The following is a description of a gene set: species: Homo sapiens Human Gene Set: chr6p21, and this is the list of marker genes: RNA5SP207, RN7SL200P, MIR5004, LTA, RNA5SP206, RPL10A, SNORA38, NFKBIL1, RN7SL502P, ARMC12, SAPCD1, HLA-DPB1, MICA, NOTCH4, UQCC2, NCR3, HSPA1B, LTB, HLA-DQB1, GRM4, USP8P1, CUL9 (cullin 9), RPL7P25, VPS52, LY6G6F-LY6G6D, ENSG00000290049, MIR6834, CRIP3, RNY4P10, C4B-AS1, LINC03040, LINC01276, BAK1, C6orf132, CYP21A1P, PSMB8, DXO, MRPL14, RPS10, RPL12P2, MIR6721, LINC02520, LY6G5B, GUCA1A, MTCO3P1, FOXP4, MOCS1, HMGA1, PPIL1, PRRT1, NPM1P51, HLA-DRB9, RNVU1-33, LY6G5C, GLP1R, SLC22A7, CLPS, C4A-AS1, HSPE1P11, MSH5, CMTR1, BNIP5, ENSG00000228559, SAPCD1-AS1, TREML5P, POLH-AS1, XPO5, TNXB, VWA7, RNU1-88P, HCP5, KLC4-AS1, IP6K3, ENPP4, FANCE, COL11A2P1, MSH5-SAPCD1 (NCBI Gene Id 100532732), ATP6V1G2, RPS18, BICRAL, TMEM63B, MRPS10, RUNX2-AS1 (RUNX2 antisense RNA 1), RN7SL811P, NFKBIE, DINOL, BTBD9-AS1, ITGAEP1, RSPH9, PPT2-EGFL8, HLA-DRB6 (NCBI Gene Id 3128), PPT2, MIR3135B, CSNK2B, AGER, C4B, PSORS1C1, ENPP5, ENSG00000293066, RPL15P4, RPL36AP5, KRT18P9, KCNK5, MIR4641 (NCBI Gene Id 100616178), HLA-S, EHMT2, ZBTB12, MIR5690, APOM, SLC35B2, CIMIP3, TFGP1, DLK2 (delta like non-canonical Notch ligand 2), MICB, ENSG00000206977, RNU6-890P, RNY3P15, KCTD20, B3GALT4, STK38, RPL32P15, DNAJC2P1 (DNAJC2 pseudogene 1), DAXX, UNC5CL, C6orf89, HLA-DQB2, KLC4, ATP6V0CP3, TAP2, BLTP3A, TFEB, ENSG00000307671, RNF8, CLIC5, MIR6873, BTBD9, ENSG00000304688, SRF, YIPF3, TNF, HLA-DRA, MIR4462, SLC29A1, HLA-DPB2, TAP1, RPL32P1, RBM22P4, SRPK1, HLA-DPA1, SNRPC, RNU6-250P, DNPH1, HLA-DQB1-AS1, PPP1R18, PHF1, KLHDC3, PBX2, HTATSF1P1, SPDEF, NRM, ANKRD36P2, RN7SL26P, TCP11 (NCBI Gene Id 6954), TREML3P, GUCA1B, MIR4647, DDAH2, LINC02976, LAP3P2, HSP90AB1, LY6G6F, GPSM3, MIR6835, RN7SL465P, FLOT1, ETV7, MIR4640, RNU6-1113P, FOXP4-AS1, IER3-AS1, ENSG00000232080, PPIAP9, ENSG00000293992, FKBPL, VARS2, PPP1R2P1, RN7SL353P, TREM1, ATF6B, HCG22, ANKRD18EP, NELFE, TREM2, AGPAT1 (NCBI Gene Id 84827), FRS3, HLA-DOA, HNRNPA1P2, MUC21, DDR1-DT, SNORD52, KIFC1, TEAD3, C6orf226, C2, ATAT1, TAPBP, ZBTB22, CCHCR1, PSMB8-AS1, USP49, OARD1, COX6A1P2, SRSF3, RPL7P4, C6orf47-AS1, GNMT, LHFPL5, MIR7159, RPL35P2, ANKS1A, MDC1-AS1, CYCSP55, SLC39A7, TBC1D22B, SMIM40, ENSG00000226454, E2F4P1, BYSL, GNL1, C6orf15, RN7SL403P, ZFAND3, RN7SL285P, PANDAR, ZDHHC20P2, MIR6833, RPL36P9, COL11A2, ENSG00000283573, DAAM2-AS1 (DAAM2 antisense RNA 1), RNU6-754P, ABHD16A, SPATS1, BRPF3-AS1 (BRPF3 antisense RNA 1), PGC, NCR2, LINC00951, MIR3925, LRFN2, MYMX, LRRC73, ILRUN-AS1, MIR1236, RNU6-761P, WDR46, SAYSD1, HLA-DOB, APOBEC2, TNXA, NAPGP2, ENSG00000295882, MIR7111, HLA-DPA2 (NCBI Gene Id 646702), RNU6-603P, TREML2, HSPA1L, CUL7, TOMM6, DDX39B, GTPBP2, DNAH8-DT, GTF2H4, POLH, TBCC, SYNGAP1, KIF6, ZNF76, RNU1-54P, LSM2, ENSG00000284954, MCCD1, EHMT2-AS1, LINC02569, C4A, TSPO2, ENSG00000252218, ZNF318, TULP1, BTNL2, RPL35AP4, BAG6, MIR586, MICA-AS1, ATP6V1FP1, BRD2, HLA-DMB, ITPR3, SNORD84, ENSG00000301948, SNORD48, DPRXP2, SUPT3H, LYPLA2P1 (NCBI Gene Id 92067), RING1, EXOSC8P1, SKIC2, PPARD, RN7SKP186, RN7SL273P, LINC02571, MLN, TRERF1, WASF5P, ENSG00000308921, ENSG00000289456, VARS1 (NCBI Gene Id 7407), UQCRHP1, UBR2, PSORS1C2, TTBK1, NUDT5P1, CLPSL1, MRPS18B, VEGFA, MED20, SLC44A4, SCUBE3-AS1, ANKRD39P1, RPL34P14, HCG25, RPL23P6, LINC00336, MDGA1, MPIG6B, PTMAP1, NUDT3, RAB44, RNU1-61P, HLA-C, RN7SL748P, HLA-B, CFB, MIR877, RPL12P1, ENSG00000304146, HCG20, STK19B, NFYA, RXRB, HLA-DPA3, RUNX2, HLA-DMA, CLPSL2, MIR6832, MAPK13, PI16, RPL3P2, PEX6 (NCBI Gene Id 5190), PTCRA, MIR4646, CLIC1, TMEM217B, MIR1275 (NCBI Gene Id 100302123), STK19, AIF1, HCG21, IFITM3P3, ITPR3-AS1, LINC00243, RPL12P47, MUCL3, MIR219A1, KCNK16, MAD2L1BP, FGD2, LINC01512, DHFRP2, MRPL2, DHX16, LINC01149, CDSN, EGFL8, CCDC167, RNU6-850P, PRPH2, PPP1R10, CUTA, LINC01016, TJAP1, POLR1C, MICB-DT, SCIRT, SLC26A8, PTK7, POLR2LP1, HLA-DRB5, FKBP5, HSD17B8, RNU6-643P, GLO1, ABCC10, RPS10-NUDT3, KCNK17, GPR166P, DNAH8-AS1, RPS10P13, HLA-DQA2, PSORS1C3, ZNF70P1, ILRUN, ENSG00000293636, TSBP1-AS1, LINC02570, TSBP1, IER3, LINC02537, DNAH8, GUCA1ANB-GUCA1A, SNHG32, PXT1, MIR4642, TMEM151B, MKRN6P, TREML4, ENSG00000272217, ENSG00000212579, RPS15AP19, ENSG00000289047, DEF6, SNORD117, RPS2P29 (NCBI Gene Id 93638), ZFAND3-DT, CAPN11, MIR6780B, LY6G6C, LST1, TCTE1, HCG27, HLA-Z, LY6G6D, TCF19, SYNGAP1-AS1, MIR6891, NUDT19P4, RNU6-1133P, PSMB9, RPS2P28, CYP21A2, PPP2R5D, RRP36, ADCY10P1, TAF11, RNF5, POU5F1, CNPY3, MUC22, PIM1, C6orf47, MDFI, ETV7-AS1, DDR1, ABCF1, SCUBE3, PFDN6, CMPK1P1, MEA1, PRRC2A, HLA-DRB1, HLA-DQA1, DDX39B-AS1, C2-AS1, GPANK1, NEU1, BRPF3, TUBB (NCBI Gene Id 95295), C6orf136 (chromosome 6 open reading frame 136), TAF8, DAAM2, TUBBP9, FGFR3P1, CDKN1A, PNPLA1, AARS2, MYL12BP3, MTCH1, LY6G6E, MDC1, RPL7L1, MIR3934, TREML1, PRICKLE4, SFTA2, RPL24P4, CCND3, MRPS18A, CPNE5, TDRG1, TMEM217, SMIM29, ENSG00000212586, GGNBP1, CDC5L, PRR3, HSPA1A, HCG24, RGL2, HLA-DQB3, RPL29P16, RNU6-283P, ATP6V1G2-DDX39B, LEMD2, PACSIN1, MAPK14, ZBTB9